Given this list of marker genes Slc10a4-ps, Slc10a4, Slc10a3, Slc10a5, Slc10a6, Slc10a2, Slc10a1, here is a description of the gene set: Mouse Gene Set: GOMF_BILE_ACID_SODIUM_SYMPORTER_ACTIVITY species: Mus musculus Enables the transfer of a solute or solutes from one side of a membrane to the other according to the reaction: bile acid(out) + Na+(out) = bile acid(in) + Na+(in).